Given this list of marker genes PIK3CA, NRAS, HRAS, KRAS, AKT2, SOS2, FLT3, PIK3CB, AKT3, PIK3CD, GRB2, BAD, SOS1, AKT1 (NCBI Gene Id 207), here is a description of the gene set: Duplication or mutation-activated FLT3 to RAS-PI3K signaling pathway. Pathway ID: N00031. Pathway type: Variant. Pathway class: nt06275 Acute myeloid leukemia. Pathway Definition from KEGG: FLT3* -> GRB2 -> SOS -> RAS -> PI3K -> PIP3 -> AKT -| BAD Human Gene Set: KEGG_MEDICUS_VARIANT_DUPLICATION_OR_MUTATION_ACTIVATED_FLT3_TO_RAS_PI3K_SIGNALING_PATHWAY species: Homo sapiens